The following is a description of a gene set: This event has been computationally inferred from an event that has been demonstrated in another species.<p>The inference is based on the homology mapping from PANTHER. Briefly, reactions for which all involved PhysicalEntities (in input, output and catalyst) have a mapped orthologue/paralogue (for complexes at least 75% of components must have a mapping) are inferred to the other species. part of: Neurotransmitter receptors and postsynaptic signal transmission electronically inferred by orthology from the curated human pathway species: Mus musculus Reactome Pathway: Activation of kainate receptors upon glutamate binding, and this is the list of marker genes: Gngt1, Gng8, Gnb2, Gng3, Dlg4, Gngt2, Dlg3, Gng5, Gng4, Grik5, Gng10 (NCBI Gene Id 14700), Calm1, Gnb5, Plcb3, Gng7, Gng11, Gnb3